Given this list of marker genes LERFS, CDK2AP2P3, RNA5SP284, ENSG00000303694, ENSG00000309584, MYO5BP3, CDRT15P7, ENSG00000235659, RPL7AP76, MYO5BP2, AQP7P4, CNTNAP3P1, FGF7P8, FKBP4P7, FGF7P7, IGKV1OR-2, CNTNAP3P5, FAM88C, ENSG00000288838, RNA5SP283, CDK2AP2P2, RPL7AP46, LINC01410, ANKRD20A4P, BMS1P9, ATP5F1AP7, ADGRF5P1, DUX4L50, FAM242D, SNX18P9, RBPJP7, FLJ43315, RNU6-1193P, FAM88B, RNU6-1293P, AQP7P2, BMS1P11, FAM27C, ENSG00000290559, GXYLT1P6, FAM88F, RAB28P2, FAM242E, CYP4F25P, SDR42E1P3, PTGER4P2, ENSG00000310065, FRG1JP, MIR4477B, BNIP3P4, RN7SL544P, ENSG00000275068, FGF7P6, BMS1P10, SNORA70, AQP7P1, CNN2P3, RN7SL722P, PTGER4P3, LINC01189, here is a description of the gene set: Human Gene Set: chr9q13 species: Homo sapiens